Given this list of marker genes CAMK1, CFD, CCL4, HES1, CCR3, P2RY10, MARCKSL1, SMAD7, IDO1, SYNE1, PTGDR2, IL5RA, PNPLA6, S100P, CNR2, SLC29A1, CREM, CCL3, P2RY14, ALOX15, CLC, RNASE2 (ribonuclease A family member 2), OLIG2, ADGRE1, TFF3, here is a description of the gene set: species: Homo sapiens from publication Nakajima T, Matsumoto K, Suto H, Tanaka K, Ebisawa M, Tomita H, Yuki K, Katsunuma T, Akasawa A, Hashida R, Sugita Y, Ogawa H, Ra C, Saito H (PMID 11493461) Mast cells (MCs) and eosinophils are thought to play important roles in evoking allergic inflammation. Cell-type--specific gene expression was screened among genes in human MCs and eosinophils with the use of high-density oligonucleotide probe arrays. In comparison with other leukocytes, MCs expressed 140 cell-type--specific transcripts, whereas eosinophils expressed only 34. Among the transcripts for expected MC-specific proteins such as tryptase, major basic protein (MBP), which had been thought to be eosinophil specific, was ranked fourth in terms of amounts of increased MC-specific messenger RNA. Mature eosinophils were almost lacking this transcript. MCs obtained from 4 different sources (ie, lung, skin, adult peripheral blood progenitor--derived and cord blood progenitor--derived MCs, and eosinophils) were found to have high protein levels of MBP in their granules with the use of flow cytometric and confocal laser scanning microscopic analyses. The present finding that MCs can produce abundant MBP is crucial because many reports regarding allergic pathogenesis have been based on earlier findings that MBP was almost unique to eosinophils and not produced by MCs. (Blood. 2001;98:1127-1134) Top 30 increased eosinophil specific transcripts. Human Gene Set: NAKAJIMA_EOSINOPHIL